Given this list of marker genes KAT2B, MDM1 (NCBI Gene Id 56890), BRCA1, TMEM67, KAT2A, TRIM37, RBM14, NPM1, CCNF, NUBP1, CENATAC, CDK5RAP2, here is a description of the gene set: Any process that decreases the frequency, rate or extent of centrosome duplication. Centrosome duplication is the replication of a centrosome, a structure comprised of a pair of centrioles and peri-centriolar material from which a microtubule spindle apparatus is organized. Human Gene Set: GOBP_NEGATIVE_REGULATION_OF_CENTROSOME_DUPLICATION studied in species Homo sapiens